The following is a description of a gene set: An acute inflammatory response to an antigenic stimulus. An acute inflammatory response occurs within a matter of minutes or hours, and either resolves within a few days or becomes a chronic inflammatory response. species: Homo sapiens Human Gene Set: GOBP_ACUTE_INFLAMMATORY_RESPONSE_TO_ANTIGENIC_STIMULUS, and this is the list of marker genes: NLRP6, BTK, IGHG1, EXT1, IL31RA, NPY5R (neuropeptide Y receptor Y5), SPN, CD6, FUT7, FCGR2A, IGHE, GATA3, FCER1G, IL20RB, FCER1A, PLA2G2D, NPY, FCGR1BP, FCGR3A (NCBI Gene Id 2214), SELENOS, FCGR3B, PARK7, HLA-E, MIR302E, CCR7 (NCBI Gene Id 1236), ZP3, NPFF, FCGR1A, ELANE, C3, FCGR2B, FCGR2C